The following is a description of a gene set: Human Gene Set: GOBP_NEGATIVE_REGULATION_OF_FILOPODIUM_ASSEMBLY studied in species Homo sapiens Any process that stops, prevents, or reduces the frequency, rate or extent of the assembly of a filopodium, a thin, stiff protrusion extended by the leading edge of a motile cell such as a crawling fibroblast or amoeba, or an axonal growth cone., and this is the list of marker genes: RAB3IP, SRGAP2C, PRKCD, NRXN1, ARHGAP44